The following is a description of a gene set: studied in species Homo sapiens from publication Travaglini KJ, Nabhan AN, Penland L, Sinha R, Gillich A, Sit RV, Chang S, Conley SD, Mori Y, Seita J, Berry GJ, Shrager JB, Metzger RJ, Kuo CS, Neff N, Weissman IL, Quake SR, Krasnow MA (PMID 33208946) Human Gene Set: TRAVAGLINI_LUNG_DIFFERENTIATING_BASAL_CELL, and this is the list of marker genes: CLDN1, KRT17, MDH2, EHF, CSTA, BAG1, SERPINB13, AP2M1, TRIM7, PLEKHS1, OAT (ornithine aminotransferase), ATP1B3, TSPAN1, NFIA, PERP, NSG1, CAMK1D, EEF1A1 (eukaryotic translation elongation factor 1 alpha 1), SYNGR1, PDHB, EPAS1, CALML3, EYA2, NUDT8, SULT2B1, VAV3 (NCBI Gene Id 10451), LARP6, RPL3, SERPINB5, LMO4, RHOC, HCAR2 (hydroxycarboxylic acid receptor 2), GAPDH, CLEC2B, CHL1, MLF2, ERN2, ALDH2, FAM3B, FOXN3, ZFYVE21, FMO2, SERPINB4, IGFBP4 (NCBI Gene Id 3487), GPR87 (NCBI Gene Id 53836), BEND5, DPYSL3, ASS1, HES4, SORL1, LYPD6B, CHP2, DDIT4, SERPINB3, GLUL, TPI1, TSPAN8, LAYN, F3, UQCRH, NDUFA8, TSHZ2, VILL, SERPINB7, GLTP (NCBI Gene Id 51228), MARCKS, PITX1, LRATD1, KRT5, CTSD (NCBI Gene Id 196214), PYCARD, ECE1, HS3ST1, DHRS3, DHRS9 (dehydrogenase/reductase 9), SERPINF1, WFDC2, CTSB (NCBI Gene Id 3896), AQP5, PGAM1, PRSS23, GALNT6, SLITRK6 (NCBI Gene Id 84189), NDRG2, STEAP1, TLE5, LAD1, EPRS1, PLEKHA5, UPK1B, CYP2J2, TACSTD2, EPHX3, ST6GALNAC1 (NCBI Gene Id 55808), FBLN1, GSN, SDC1, EIF3F, AQP3, SOX2, RPL13A, PSMC5, ETHE1, BBLN, ALDH1A1, IFI16, AKR1A1, CTSC, RPS4X, TSPO, S100A2 (S100 calcium binding protein A2), ANXA1, SYTL1 (NCBI Gene Id 84958), HMGB3, ADH1C, MIR205HG, POLD4, NDUFV1, TMPRSS4, TCF4, GSTP1, FAM3D, A4GALT, RPSA, MDK, AGR2, TNFSF10, HEY1, S100A16, ADORA2B (NCBI Gene Id 136), CAPNS2, IGFBP3, CHST9, CD82, KRT19, LIMA1, PRR15, KLK11, CAPN1, BHLHE40, ALOX15, CMTM7, CLCA2, CXCL1, UQCRC1, KLF5, TUFM, PPP1CA, SLC1A5, NHERF1, ADH7, PAFAH1B3 (platelet activating factor acetylhydrolase 1b catalytic subunit 3), DAPL1, CLDN10, RIPK4, FAM107A (NCBI Gene Id 50803), SNCG